The following is a description of a gene set: Reactome Pathway: NuRD complex assembly part of: CHD3, CHD4, CHD5 subfamily The nucleosome remodeling and deacetylase (NuRD) complex is a multi-protein ATP-dependent chromatin remodeler that, uniquely, combines histone deacetylase activity with ATPase and DNA translocase activities. In humans, the ATPase activity is provided by one of three CHD proteins, CHD3, CHD4 or CHD5, each of which assemble into NuRD complexes with overlapping but distinct composition and roles (Le Guezennec et al, 2006; Kolla et al, 2015; Nitarska et al, 2016; reviewed in Alendar and Berns, 2021; Asmamaw et al, 2024). Histone deacetylase activity is contributed by either HDAC1 or HDAC2. In addition, the NuRD complex contains five additional core components, each of which exists in humans as members of paralogous protein families: metastasis-associated protein 1 (MTA1), MTA2 or MTA3; RBBP4 or RBBP7; methyl-CpG-binding domain protein 2 (MBD2) or MBD3; GATAD2A or GATAD2B; and cyclin-dependent kinase 2-associated protein 1 (CDK2AP1) or CDK2AP2. NuRD complex assembly is thought to nucleate around a core complex consisting of HDAC1/2, MTA1/2/3 and RBBP4/7, to which the other subunits are then recruited. The compositional diversity of NuRD complexes has made categorically defining complex stoichiometry and structure challenging, so although numerous structures of individual components or subcomplexes have been solved, no complete structure exists. Although NuRD complexes were initially identified as transcriptional repressors, it is now appreciated that they can act as activators as well. Although many components of the complex are able to interact with DNA and/or histones, recruitment of NuRD to target genes is predominantly mediated by interaction with transcription factors; <br>In addition to being part of the NuRD complex, subfamily II CHD proteins may also be part of other chromatin modifying complexes, such as the CHD4-ChADH complex, and have indeed been shown to have chromatin sliding activity in vitro in the absence of interacting protein partners. studied in species Homo sapiens, and this is the list of marker genes: HDAC1, H2AC4, H2BC13, IKZF3, H2BC3, MTA1, H2AC7, G6PC1, CHD3, H2BC11 (NCBI Gene Id 8970, H2B clustered histone 11), H2AX, H2AC20, MBD2, GATAD2A, IKZF2, CDK2AP1, ZNF687, MBD3L2, H2BC15, GATAD2B, H2AZ2, H2BC14, NR2F2, H2AJ, ZNF827, MBD3L1, PCK1, H2BC1, H2BC12, H2BC21, ZNF592, H3C15, PHF6, HDAC2, RBBP4, TCF19, IKZF1, H2BC26 (NCBI Gene Id 128312), H3C1, PWWP2B, CHD5, MTA3, SUMO1, H2BC12L, H2BC5, MBD3, CHD4, ZNF532, H4C1, ZMYND8, H2BC17, H3-3A, H2BC4, FBP1, MTA2, PWWP2A, NR2C2, RBBP7, H2AC14, UBE2I, H2AC6, H2BC9, H2AB1, H2AC18, CDK2AP2